The following is a description of a gene set: To better define the molecular basis of multiple myeloma (MM), we performed unsupervised hierarchic clustering of mRNA expression profiles in CD138-enriched plasma cells from 414 newly diagnosed patients who went on to receive high-dose therapy and tandem stem cell transplants. Seven disease subtypes were validated that were strongly influenced by known genetic lesions, such as c-MAF- and MAFB-, CCND1- and CCND3-, and MMSET-activating translocations and hyperdiploidy. Indicative of the deregulation of common pathways by gene orthologs, common gene signatures were observed in cases with c-MAF and MAFB activation and CCND1 and CCND3 activation, the latter consisting of 2 subgroups, one characterized by expression of the early B-cell markers CD20 and PAX5. A low incidence of focal bone disease distinguished one and increased expression of proliferation-associated genes of another novel subgroup. Comprising varying fractions of each of the other 6 subgroups, the proliferation subgroup dominated at relapse, suggesting that this signature is linked to disease progression. Proliferation and MMSET-spike groups were characterized by significant overexpression of genes mapping to chromosome 1q, and both exhibited a poor prognosis relative to the other groups. A subset of cases with a predominating myeloid gene expression signature, excluded from the profiling analyses, had more favorable baseline characteristics and superior prognosis to those lacking this signature. Top 50 up-regulated genes in cluster CD-2 of multiple myeloma samples with the characteristic expression spike of CCND3. Human Gene Set: ZHAN_MULTIPLE_MYELOMA_CD2_UP from publication Zhan F, Huang Y, Colla S, Stewart JP, Hanamura I, Gupta S, Epstein J, Yaccoby S, Sawyer J, Burington B, Anaissie E, Hollmig K, Pineda-Roman M, Tricot G, van Rhee F, Walker R, Zangari M, Crowley J, Barlogie B, Shaughnessy JD Jr (PMID 16728703) species: Homo sapiens, and this is the list of marker genes: APLP2, SLC8A1, LINC02397, LRRK2-DT, MARCKS, ATP2B1-AS1, ZNF395, SRC, NAGK, LAMA2, DYRK2, NF1, DUSP22, VPREB3, FCRLB, PNOC (NCBI Gene Id 5368), PDZRN4, DHTKD1, ITPKB, PTPRJ, MS4A1, TGIF1, CD27, CNPPD1, PLPP3, SDC2, METRNL, PAX5, RERE, RNGTT, ZNF608, CD79A, DTX1, TNFSF8, PHLPP2, ADSS1, SPAG4, TNFRSF13C, TRAF5, PLXNB2, RCBTB2, B3GALNT1, PIK3AP1, SORT1, BEND5, PRDM5, RGS13, CNR1